Given this list of marker genes GPR37L1, APLNR, TACR2, MC1R, LTB4R2, PRLHR, GUCY2F, GLP1R, HCRTR1, GRPR, CRHR1, BDKRB1, MCHR2, GPR139, NMBR, OGFR, GP1BA, CALCRL, LHCGR, MC3R, CCKBR, NTSR1, NPR1, GIPR, GPR171, RAMP1, NPFFR2, CALCR, NMUR1, CCKAR, MC5R, SORCS3, OPRK1, MCHR1, AGTR1, GPRC6A, NPBWR2, VIPR2, GLP2R, S1PR2, NPBWR1, QRFPR, GALR3, NMUR2 (NCBI Gene Id 56923), PTH1R, INPP5K, OPRL1, NPSR1, CRCP, PROKR2 (prokineticin receptor 2), NLRP6, OGFRL1, EDNRB (NCBI Gene Id 3282), PTH2R, GPR143, AVPR1B, MRGPRD, UTS2R, F2RL1, CX3CR1, GPR84, FPR2, SSTR2, SCTR, GALR2, AVPR2, MLNR, SSTR3, SSTR5, PROKR1, NPFFR1, NPR2, GPR37, BRS3, AVPR1A, MC4R, NPY2R, GUCY2C, CRHR2, HCRTR2, GALR1, NPY4R, RXFP4, GCGR, RXFP1, SORCS2, TSHR, BDKRB2, AGTRAP, TACR3, RXFP2, RXFP3, RAMP2, LTB4R, MAS1, NPY1R, OXTR, MC2R, RAMP3, SSTR4, NPY5R, GUCY2D, NPY4R2, GPR83, GPR32, TACR1, GAL, EDNRA, NTSR2 (neurotensin receptor 2), FPR1, CYSLTR1, NPR3 (natriuretic peptide receptor 3), SORCS1, OPRD1, F2RL3, KISS1R, FBXW7-AS1, FPR3, GHRHR, SSTR1, F2R, F2RL2, OPRM1, VIPR1, GPR32P1, AGTR2, FSHR, ADCYAP1R1, CYSLTR2, NPY6R, here is a description of the gene set: Combining with an extracellular or intracellular peptide to initiate a change in cell activity. studied in species Homo sapiens Human Gene Set: GOMF_PEPTIDE_RECEPTOR_ACTIVITY